Given this list of marker genes MAGI2, AKT1, AKT3, AKT2 (AKT serine/threonine kinase 2), MAGI1, PTEN, here is a description of the gene set: Human Gene Set: KEGG_MEDICUS_REFERENCE_MAGI_PTEN_SIGNALING_PATHWAY Pathway Definition from KEGG: MAGI -> PTEN -| PIP3 -> AKT MAGI-PTEN signaling pathway. Pathway ID: N00342. Pathway type: Reference. Pathway class: nt06166 Human papillomavirus (HPV). species: Homo sapiens